The following is a description of a gene set: studied in species Homo sapiens Reactome Pathway: Toxicity of botulinum toxin type F (botF) Botulinum toxin type F (botF) is only very rarely associated with human disease and a pathway by which it might enter the circulation from the human gut has not been described. Nevertheless, the toxin itself, a disulfide-bonded heavy chain (HC) - light chain (LC) heterodimer ("dichain"), is capable of binding to neurons by interactions with cell-surface ganglioside and synaptic vesicle protein 2 (SV2), the bound toxin can enter synaptic vesicles and release its LC moiety into the cytosol of targeted cells, and the botF LC can cleave vesicle-associated membrane proteins 1 and 2 (VAMP1 and 2) on the cytosolic face of the synaptic vesicle membrane. These four events are annotated here. part of: Neurotoxicity of clostridium toxins, and this is the list of marker genes: botF, SV2C, SV2B, VAMP2, SV2A, VAMP1